The following is a description of a gene set: studied in species Mus musculus electronically inferred by orthology from the curated human pathway Reactome Pathway: SHC1 events in ERBB4 signaling This event has been computationally inferred from an event that has been demonstrated in another species.<p>The inference is based on the homology mapping from PANTHER. Briefly, reactions for which all involved PhysicalEntities (in input, output and catalyst) have a mapped orthologue/paralogue (for complexes at least 75% of components must have a mapping) are inferred to the other species. part of: Signaling by ERBB4, and this is the list of marker genes: Shc1, Erbb4, Grb2, Nrg3, Btc, Hras